Given this list of marker genes SLC22A4, ALDH7A1, BHMT (betaine--homocysteine S-methyltransferase), CHDH, SLC44A1, DMGDH, SARDH, SLC44A2, here is a description of the gene set: Choline is an essential water-soluble nutrient in humans, serving as a precursor of phospholipids and the neurotransmitter acetylcholine. It is often associated with B vitamins based on its chemical structure but it isn't an official B vitamin. Its oxidation to betaine provides a link to folate-dependent, one-carbon metabolism where betaine is a methyl donor in the methionine cycle. Betaine is further metabolised to dimethylglycine which is cleared by the kidney. studied in species Homo sapiens part of: Metabolism of amino acids and derivatives Reactome Pathway: Choline catabolism